Given this list of marker genes RPN1, DDOST, DAD1, RPN2, OST4, STT3A, TMEM258, OSTC, here is a description of the gene set: studied in species Homo sapiens An oligosaccharyltransferase complex that contains STT3A as the catalytic subunit. Human Gene Set: GOCC_OLIGOSACCHARYLTRANSFERASE_COMPLEX_A